Given this list of marker genes GPX1, CYP1B1, PRDX6, GPX2, FTH1, XDH, CAT, FTL, SDC4, PRDX3, TXN, PRDX1, SOD3, CP, HMOX1, MT1X, GLRX2, SOD2, TXNRD2, TXN2, GPX5, TXNIP, HPX, GSR, MT1F, PRDX2, PRDX4, GCLM, SOD1, GPX3, GPX4, GLRX, SCAF4, HP, TXNRD1, HMOX2 (heme oxygenase 2), here is a description of the gene set: studied in species Mus musculus Insulin resistance is a cardinal feature of type 2 diabetes and is characteristic of a wide range of other clinical and experimental settings. Little is known about why insulin resistance occurs in so many contexts. Do the various insults that trigger insulin resistance act through a common mechanism? Or, as has been suggested, do they use distinct cellular pathways? Here we report a genomic analysis of two cellular models of insulin resistance, one induced by treatment with the cytokine tumour-necrosis factor-alpha and the other with the glucocorticoid dexamethasone. Gene expression analysis suggests that reactive oxygen species (ROS) levels are increased in both models, and we confirmed this through measures of cellular redox state. ROS have previously been proposed to be involved in insulin resistance, although evidence for a causal role has been scant. We tested this hypothesis in cell culture using six treatments designed to alter ROS levels, including two small molecules and four transgenes; all ameliorated insulin resistance to varying degrees. One of these treatments was tested in obese, insulin-resistant mice and was shown to improve insulin sensitivity and glucose homeostasis. Together, our findings suggest that increased ROS levels are an important trigger for insulin resistance in numerous settings. Human Gene Set: HOUSTIS_ROS Genes known to modulate ROS or whose expression changes in response to ROS from publication Houstis N, Rosen ED, Lander ES (PMID 16612386)